Given this list of marker genes Xdh, Ada, Ak2, Aprt, Nt5c1b, Prps2, Adsl, Pfas, Ampd1, Ak4, Adss1, Entpd1, Nudt2, Uox, Atic, Urah, Slc29a1, Ak3, Gart, Ampd2, Adss2, Nt5e, Nt5c1a, Paics, Ampd3, Pnp, Adk, Ppat, Hprt1, Urad, Ak1 (NCBI Gene Id 59018), here is a description of the gene set: The chemical reactions and pathways involving AMP, adenosine monophosphate. studied in species Mus musculus Mouse Gene Set: GOBP_AMP_METABOLIC_PROCESS